Given this list of marker genes NKIRAS1, DCK, COL27A1, CHST10, TNK2, RSRP1, SAFB2, POLG, ATG4D, KCTD2, SLC25A37, DENND4C, RAP2C, PAFAH1B1, JUP, PPP2CA, SERTAD2, FBXW7, RCSD1, ZNF770, MIA3, POU6F1, RAG2, ARSA, CCDC126, VPS13D, AP3M2, GIGYF1, ACIN1, ZNF592, PIP4P1, ZNF653, ZNF335, PPP6R3, DAPK1, TP53I13, CCDC71L, CASK, TBCEL, ZNF512, SMPD2, KLHDC8B, LYPD8, LDHB (NCBI Gene Id 3945), IRF5, SSH3, RNPEPL1, GLCCI1, ATP7A, PCDHB12, RNF123, C8orf58, STAT2, RAB11B, TMCC3, PSAP, WNT8B, ARMCX3, FHIP2A (FHF complex subunit HOOK interacting protein 2A), NAA11, SASH1, HARBI1, STEAP2, IFT140, APOC1, CROT, ITGA5, ZBTB42, UBP1, ZBTB20, MED13, PABPN1, GLG1 (NCBI Gene Id 2734), KHDC4 (NCBI Gene Id 22889), PNKP, ADAMTS7, ADGRL3, TOX4, TMCC1, KREMEN1, FBXW5, AP1M1, R3HCC1L, CNOT6, PBX2, KRT25, LZTFL1, MAST3, TMEM120B, ATP11A, ALDH7A1, TSGA10, CCNG2, LENG8, TTLL3, EMSY, ELK4, NBR1, IL4R, BRPF1, LZIC, ANXA10, AKAP8L (A-kinase anchoring protein 8 like), ABCC3, ACADS, FCSK, CORO7 (NCBI Gene Id 79585), CTSV, EZH1, PPP1R21, USP32 (ubiquitin specific peptidase 32), SETD4, TIAM1, DYNLT5, YPEL2, EPS15, MIER1, CELSR2, PLEKHG2, FAM8A1, STK24, SLC25A12, ZBTB18, SFI1, NFRKB, CERK (ceramide kinase), UBR3, ITPKB, MAPK9 (mitogen-activated protein kinase 9), TSC22D4, TNFRSF12A, BTBD8, EXOC2, TAP2, CLK3, ATP6AP2, NMNAT1, RPRML, KLK6, STEEP1, EFHD2, ATP6V1G1, KIF5B, PRAMEF8, TRIM56, LRRC28, FGF2, CRYBA2, RAD52, KRBA1, RMND5A, ZNF750, CLEC4E, UBE2H, TTLL1, TNFSF9, ZNF29P, MMP19, DLG3, MSANTD1, FAM193B, NDFIP2, PABPC1L, FAM210B (family with sequence similarity 210 member B), ANKHD1, CD4, DTX3, IL10, DCTN1, MARCHF6, RASA1, PSEN1, ZFYVE1, USF3, MALAT1 (NCBI Gene Id 378938), ZNF287, BBS4, MAFB, NAV2, SLC24A2, TRAT1, ADGRE5, SKIDA1, HELZ, UNC5CL, RGMA, RNF41, HMGB4, PTPN14, AQP11, ZNF446, BBOF1, ETS2, HBP1, ILKAP, MARK4, WBP1, TEPSIN, LAMC1, SIRT7 (NCBI Gene Id 51547), here is a description of the gene set: from publication Choi YI, Duke-Cohan JS, Ahmed WB, Handley MA, Mann F, Epstein JA, Clayton LK, Reinherz EL (PMID 19027330) Genes up-regulated in comparison of CD4 CD8 thymocytes versus CD4 Int CD8 thymocytes. T cell development relies on the precise developmental control of various cellular functions for appropriate positive and negative selection. Previously, gene expression profiling of peptide-driven negative selection events in the N15 TCR class I MHC-restricted mouse and D011.10 TCR class II MHC-restricted mouse has offered insights into the coordinate engagement of biological processes affecting thymocyte development. However, there has been little comparable detailed in vivo global genome expression analysis reported for positive selection. We used microarrays to identify the genes differentially expressed during CD8 single positive T cell development in N15 TCR transgenic Rag2 deficient mice. Human Gene Set: GSE13493_DP_VS_CD4INTCD8POS_THYMOCYTE_UP studied in species Homo sapiens